The following is a description of a gene set: Human Gene Set: FOXO4_02 species: Homo sapiens Genes having at least one occurrence of the motif NNGTTGTTTACNTN in the regions spanning 4 kb centered on their transcription starting sites. This matches the MLLT7 transcription factor binding site V$FOXO4_02 (v7.4 TRANSFAC)., and this is the list of marker genes: PRDM1, TGIF1, PLAG1, CELF6, CRH, SEPTIN4, SNCAIP, ZBTB18 (NCBI Gene Id 10472), RARB, CNGB3, GTF2A1L, OTUD7B, FRY (FRY microtubule binding protein), ID2 (inhibitor of DNA binding 2), ORC4, EMP1, VSIG10 (NCBI Gene Id 54621), LOX, LDB1 (LIM domain binding 1), NSD3, CADM1, SH3GL3, PALS2, BRD8, TNFSF4, ITGB8, STOML3 (NCBI Gene Id 161003), HAS2, FOXO1, BCLAF3, PITPNC1, ADGRF1, MEOX2, SMAD5, NDUFB2, CPA2, PTCH1, TIAM1, NRG1, JAG1, FGF12, LRP5, ARL4C, NR3C1, ZNF521, LZTS2, FOXP2, CACNA2D1, IKZF2, STAG2, SELENOI, DTNA, NFIX, PDZRN4, HBP1, CITED2, TAFAZZIN, SCUBE3, ZNF827, TMEM71, ELAVL2, ZNF277, MDGA1, RBFOX1, JPH3 (NCBI Gene Id 57338), BCL7A, ZBTB9, ELOVL6, MRFAP1, KDM3A, TEX2, DNAH17, CREBL2, NTN1, HMCN1, SALL3, XPO7, LCP2, SUMO1, IRS4, ATXN1, TRIM8, MCM7, APOM, RFX3, HOXB8, PURA, MEOX1, TNRC6A, ASXL1, KIF20A, NXN, DIDO1, HLX, AQP2, PRUNE1, AAMDC, NFATC3, MARCKSL1, GFRA1, TFAP4, WIPI2, LIX1L, RBP2, IL1RAPL1, TBC1D17, PAQR9, KRT85, FGF9, KLF12, HR, MXRA8 (NCBI Gene Id 84308), XKRX, PHLPP1, HEBP2, EIF4G2, ESR2, PTGR3, SQSTM1, EML1, SELENOP (selenoprotein P), THRA, KDM6A, LMO3, CHCHD7, KCNJ5, PPP2R1B, LHX9, NNAT, TBCC, RASGEF1B, TXNDC12, HS3ST1, HOXC8, UBE2H, FLNC, AKT1S1, GFI1B, NUB1 (NCBI Gene Id 51667), SMAD1, IRF4, ETV5, PAPPA, AP4M1, LEMD1, BUB3, SLC10A7, TXNIP, DIXDC1, ARID1B (AT-rich interaction domain 1B), GNAS, KLHL24, HTN1, VSIG2, NXPH3, PDCD4, TGFB3, MACO1, SATB2, NRN1L, NR4A2, GRB7, NEDD4, CXCR5, JADE2, MAPK10, SASH1, CNR1, PKN2, TSSK2, CCDC89, EFNA1, C12orf50, ZMAT4 (NCBI Gene Id 79698), SCRN3, FUZ (NCBI Gene Id 80199), EHD1, MEIS2, BDNF, CXXC5, KLF5, CLPX, SLC26A7, FSBP, ERG, SREK1, IKZF4, TMPRSS15, ZNF362, RASD1 (ras related dexamethasone induced 1), MRGPRF, TIGD4, EZH1, IL6ST, ARFGEF1, FOXP3, PALM, MINDY1, KMT2A, UGCG, PDK4, CDKN1C, SLC38A3 (NCBI Gene Id 10991), HOXB4, PITX2, INSR, TCF15, ACVR1B, GPR137B, CRTC2, NTRK3, POLR2L, HOXC4, GRAP2, USP3, CFL2, RUNX1, VCPKMT, WBP1L, GPR174, MAFF, CASC2, ARID4A, KREMEN1, SCN3A, UBE2O, NPAS3, TBX4, CREBRF, SLMAP, PDE7A, ZFYVE9, PHF21A, ARFIP1, EXOSC9, NR1D1, RSF1, TMEM196, DOCK4, PLXDC2, TEK, COX7B, LRRC1, PDGFD, CSRNP3, GNAO1, DLL1 (delta like canonical Notch ligand 1), TRPC4, NAP1L5, RUNX1T1, ENPP2, TRERF1, TSPAN4, SKAP1, PLEKHA5, CLC, COL8A1, DCX, PIK3IP1, RAB6A, CHD2, PCDH18, FAM53C